The following is a description of a gene set: species: Homo sapiens Human Gene Set: REACTOME_GP1B_IX_V_ACTIVATION_SIGNALLING GP1b-IX-V activation signalling, and this is the list of marker genes: PIK3R1, GP5, COL1A1, RAF1, YWHAZ, VWF, GP9, GP1BA, FLNA, GP1BB, COL1A2, SRC